The following is a description of a gene set: species: Homo sapiens Any process that modulates the frequency, rate or extent of cyclin-dependent protein serine/threonine kinase activity. Human Gene Set: GOBP_REGULATION_OF_CYCLIN_DEPENDENT_PROTEIN_SERINE_THREONINE_KINASE_ACTIVITY, and this is the list of marker genes: CDK5R2, BLM, LATS2, TFAP4, CCNY, CCNE2, GADD45A, CDK5R1, PKMYT1, CCNK, CDKN2A, INCA1, APC (NCBI Gene Id 324), SERTAD1, DIRAS3, CDC6 (NCBI Gene Id 990), CDKN1B, CDK5RAP1, MEN1, GTF2H1, CDK5RAP3, CDC25A, CCNT1 (NCBI Gene Id 904), CCNG1, BCCIP, CDKN3, CCNT2, LATS1, PSMD10, CDC37, HERC5, CDC25C, PIM1